Given this list of marker genes EID2, SERPINB1, GPHN, PLLP, JUN, CCND1, KIF13A, AIG1, KLF7, OBSCN, CKB, CTSV, RET, PIK3CB, ISL1, CDC42BPB, MT1F, KCNQ1OT1, ATXN1, DNAI2, ATF3, CDK6, MTHFD2L, ACOXL, RAB30, CCND2, MT1X, LINC-PINT, PTPDC1, BHLHE40, RNF125, SHCBP1L, GPRASP3, AK7, PPARGC1A, CCDC91 (NCBI Gene Id 55297), CCDC126, KIAA1671, PCP4, RAB20, TLN2, ACOT1, FAM221A, SLC30A1, ABCB1, EQTN, ALCAM, FABP5 (NCBI Gene Id 92424), GPR65, CERS6, TFPI, FAM9A, ADSS1, LAPTM4B, PRSS23, NRIP1, GRIK1, ABTB2, BCL11B, GAREM1, PLA2G4A, TRMT61A, TMEM38B, VOPP1, SLC47A1, ZNF827, SFMBT2, LGALSL, KCNF1, RNF43, SMAD1, MEI4, ENAH, ZFP14, TRPS1, XIST, UCHL1, CD69, ASNS, PLK2, TSPAN4, RRAGD, here is a description of the gene set: Top up-regulated genes from principal component 3 (PCA3) which captures variation among different plasma cell tumors arising from overexpression of BCL2L1 and MYC. Human Gene Set: BOYLAN_MULTIPLE_MYELOMA_PCA3_UP Multiple myeloma is an incurable plasma cell malignancy for which existing animal models are limited. We have previously shown that the targeted expression of the transgenes c-Myc and Bcl-X(L) in murine plasma cells produces malignancy that displays features of human myeloma, such as localization of tumor cells to the bone marrow and lytic bone lesions. We have isolated and characterized in vitro cultures and adoptive transfers of tumors from Bcl-xl/Myc transgenic mice. Tumors have a plasmablastic morphology and variable expression of CD138, CD45, CD38, and CD19. Spectral karyotyping analysis of metaphase chromosomes from primary tumor cell cultures shows that the Bcl-xl/Myc tumors contain a variety of chromosomal abnormalities, including trisomies, translocations, and deletions. The most frequently aberrant chromosomes are 12 and 16. Three sites for recurring translocations were also identified on chromosomes 4D, 12F, and 16C. Gene expression profiling was used to identify differences in gene expression between tumor cells and normal plasma cells (NPC) and to cluster the tumors into two groups (tumor groups C and D), with distinct gene expression profiles. Four hundred and ninety-five genes were significantly different between both tumor groups and NPCs, whereas genes were uniquely different from NPCs in tumor group C and genes were uniquely different from NPCs in tumor group D. Similar to human myeloma, the cyclin D genes are differentially dysregulated in the mouse tumor groups. These data suggest the Bcl-xl/Myc tumors are similar to a subset of plasmablastic human myelomas and provide insight into the specific genes and pathways underlying the human disease. from publication Boylan KL, Gosse MA, Staggs SE, Janz S, Grindle S, Kansas GS, Van Ness BG (PMID 17483317) studied in species Mus musculus